Given this list of marker genes TWIST1, BMP2, SNRPN, WT1, TFAP2A, SOCS3, QDPR, GFAP, IL17A, CDH1, EDNRB, MLH1, TIMP2, TIMP3, MGMT, DAB2, SEZ6L, APOC1, FANCF, FOXN2, VCAN, CDKN2B, HIC1, SFRP5, GSTP1, CDKN2A, ME3, RARB, CALCR, CREBL2, CDH13 (NCBI Gene Id 1012), SFRP4, BRCA1, GATA5, CDX2, HOXA5, PTGS2, FHIT, RBP1, APC, PAX5, CDX1, ESR1, SFN, CHFR, SOCS1, GATA4, FABP3, GH2 (NCBI Gene Id 2689), CADM1, SFRP1, DRD4, RASSF1, RUNX3, APOD, CCND2, here is a description of the gene set: DNA methylation has a role in mediating epigenetic silencing of CpG island genes in cancer and other diseases. Identification of all gene promoters methylated in cancer cells the cancer methylome would greatly advance our understanding of gene regulatory networks in tumorigenesis. We previously described a new method of identifying methylated tumor suppressor genes based on pharmacologic unmasking of the promoter region and detection of re-expression on microarray analysis. In this study, we modified and greatly improved the selection of candidates based on new promoter structure algorithm and microarray data generated from 20 cancer cell lines of 5 major cancer types. We identified a set of 200 candidate genes that cluster throughout the genome of which 25 were previously reported as harboring cancer-specific promoter methylation. The remaining genes were tested for promoter methylation by bisulfite sequencing or methylation-specific PCR (MSP). Eighty-two of 175 (47%) genes were found to be methylated in cell lines, and 53 of these genes (65%) were methylated in primary tumor tissues. From these genes, cancer-specific methylation was identified in genes (28 of 53; 53%). Furthermore, we tested 8 of the 28 newly identified cancer-specific methylated genes with quantitative MSP in a panel of 300 primary tumors representing 13 types of cancer. We found cancer-specific methylation of at least one gene with high frequency in all cancer types. Identification of a large number of genes with cancer-specific methylation provides new targets for diagnostic and therapeutic intervention, and opens fertile avenues for basic research in tumor biology. studied in species Homo sapiens Human Gene Set: HOQUE_METHYLATED_IN_CANCER from publication Hoque MO, Kim MS, Ostrow KL, Liu J, Wisman GB, Park HL, Poeta ML, Jeronimo C, Henrique R, Lendvai A, Schuuring E, Begum S, Rosenbaum E, Ongenaert M, Yamashita K, Califano J, Westra W, van der Zee AG, Van Criekinge W, Sidransky D (PMID 18413733) Genes whose DNA was methylated both in primary tumors and across a panel of cancer cell lines.